Given this list of marker genes SKIC3, HBS1L, EXOSC7, SKIC8, EXOSC8, DCPS, EXOSC2, EXOSC3, EXOSC6, EXOSC4, DIS3, SKIC2, EXOSC5, EXOSC1, EXOSC9, NT5C3B, here is a description of the gene set: mRNA decay by 3' to 5' exoribonuclease studied in species Homo sapiens Human Gene Set: REACTOME_MRNA_DECAY_BY_3_TO_5_EXORIBONUCLEASE